Given this list of marker genes Rasa1, Irs2, Capn10, Prkci, Gsk3a (NCBI Gene Id 76828), Nfe2l2, Prkca, Opn3, Pea15a, Adipoq, C2cd5, Rtn2, Ins2, Crebl2, Akt1, Rhoq, Sh2b2, Rap1a, Mef2a, Ostn, Gpc3, Fgf21, Mapk14, Hk2, Rps6kb1, Itln1, Pid1, Ins1, Rnasel, Appl2, Enpp1, Ptpn11, Cers1, Adipor2, Myc, Erbb4, Igf1 (NCBI Gene Id 320499), Ocln, Lep, Fgf15, C1qtnf2, Osbpl8, Appl1, Prkcd, Upk3b, Erfe, Tnf, Aspscr1, Slc1a2, Sorbs1, Oga, Repin1, Pou4f2, Ahi1, Stxbp3, Grk2, Irs1 (NCBI Gene Id 16367), Erbb3, Ace, Klf15, Esr1, Slc25a27, Tert, Insr, Sirt6, Grb10, C1qtnf12 (C1q and tumor necrosis factor related 12), Akt2, Pth (parathyroid hormone), Mfn2, here is a description of the gene set: Mouse Gene Set: GOBP_REGULATION_OF_D_GLUCOSE_IMPORT Any process that modulates the frequency, rate or extent of the import of the hexose monosaccharide glucose into a cell or organelle. species: Mus musculus